Given this list of marker genes Ctnnb1, Tgfb3, Cldn34c6, Tbcd, Cdh10, Ptpn23, Grhl2, Ext1, Alox12b, Tjp3, Ugt8a, Dlg1, Cdh26, Samt4, Ccm2, Esam, Pkn2, Rdx, Cdhr18, Cxadr, Bhlha15, Snai2, Pof1b, Agt, Fer, Vegfa, Cldn16, Pak2, Epb41l3, Il1b, Tgfb1, Cdh20, Cldn15, Cldn17, Ceacam1, Wdr1, Ace, Ocln, Nr1h4, Samt1d, Cdh22, Perp, Tnf, Rhoa, Aloxe3, Pdcd6ip, Prtn3, Hnf4a, Cdc42, Lypd11, Cldn34b3 (NCBI Gene Id 238829, claudin 34B3), Cldn1, Rock2 (NCBI Gene Id 77848), Efnb2, Tjp1, Samt2b, Pkhd1, Cldn7, Pard3, Afdn, Dsp, Nfasc, Cdh3, Tgfbr1, Cdh13 (cadherin 13), Frmpd2, Cldn4, Fbf1, Nphp4, Mpp7, Cdh9 (cadherin 9), Fscn1, Jup, Ect2, Pmp22, Myo1c, Ajm1, Plec, Dlg5, Cldn11, Marveld3, Hipk1, Rps6, Cldn18, Tmigd1, Cd9, Wnt11, Il17a, Pkp4, Snai1, Prkaca, Cntnap2, Csk, Lsr, Slc39a9, Samt2, Acvrl1, Abi2, Cldn34c3, F2r, Cdh11 (NCBI Gene Id 77023), Cldn6, Cldn34a, Tgfb2, Cldn2 (claudin 2), Nf2, Cldn3, Flna, Cd177, Mpz, Prkca, Cdh2, Itgb1, Gjb6, Mpdz, Ptpro, Pkp2, Add1, Tjp2, Vcl, Samt1b, Cgn, Cdh4, Actb (NCBI Gene Id 11476), Dsg2, Pkp1, Patj, Camsap3, Rac1, Cldn34d, Cldn22, Ctnna1, Micall2, Kifc3, Cldn23, Cntnap1, Numb, Arl2, Asb17 (ankyrin repeat and SOCS box-containing 17), Aplnr, Cd2ap, Inava, Xirp2, Cav1, Lims2, Cldn19, F2rl1, Fzd5, Cldn34b1, Nphs1, Rhoc, Prkcz2, Shroom2, Cdh15, Cldn9, Rock1, Gnpat, Nedd4l, Ramp2, Cldn34c2, Cdh17, Fermt2, Cldn8, Ikbkb, F11r, Cdh24, Gjb2, Abcc8, Src, Hdac7, Specc1l, Nectin1, Gdf2, Fkrp (NCBI Gene Id 243853), Cdh1, Marveld2, Cdh8, Epha4, Irx3, Trpv4 (transient receptor potential cation channel, subfamily V, member 4), Cldn34c5, Svep1, Prkci, Cdh19, Cldn5, Mylk3, Smad7 (NCBI Gene Id 17131), Cdh7, Gjd3, Ephb2, Numbl, Srf, Smad3, Plekha7, Cldn34b4, Dsg3, Kprp, Gpbar1, Tbx5, Cldn24, Heg1, Zfp703, Crb3, Ildr1, Dsc1, Gja1, Hopx, Grhl1, Rab13, Actn4, Gjc1, Cdh6, Nphp1, Gja5, Ocel1, Bmp6, Adam10, Cldn34b2 (claudin 34B2), Cldn34c4, Cldn14, Cdh18, Kirrel1, Lims1, Mtss1, Cldn34c1, Csf1r, Ace2 (NCBI Gene Id 70008), Whrn (whirlin), Cdh5, Prkch, Cdh12, Rps6-ps4, Actg1, Flcn, Cldn13, Epha2, Cldn12, Pecam1, Lypd10, Pard6a, Pkp3, Samt3, Jam3, Cldn10, here is a description of the gene set: species: Mus musculus Mouse Gene Set: GOBP_CELL_CELL_JUNCTION_ORGANIZATION A process that is carried out at the cellular level which results in the assembly, arrangement of constituent parts, or disassembly of a cell-cell junction. A cell-cell junction is a specialized region of connection between two cells.